Given this list of marker genes ITPR1 (NCBI Gene Id 619543, inositol 1,4,5-trisphosphate receptor type 1), CASP4, ERP29, CSNK1G3, ELL2 (NCBI Gene Id 22936), ADGRL2, ABCD1, PDE4B, AZIN2, NDUFA13, GOLGA7B, CRYZ, HSDL2, SCD, PRDX4, CCS, SIDT1, TMED3, RGS10, MYH9, FERMT3, TAX1BP1, EIF2B2, BCL2L14, INSIG2, RBM43, TK1, CR1L, UBR2, PRF1, ASPM, GNA13, NXPE2, FIS1, TUT4, MXD1, CMAS, POU6F1, FTH1, MKNK2, ARID1A, RNF130, YPEL2, ARL6IP5 (ADP ribosylation factor like GTPase 6 interacting protein 5), SHARPIN (SHANK associated RH domain interactor), CEP43, ANKRD50, KLF12, FXYD4, SLC39A13, SNX14, TRIB2, SCAND1, GPI, GABPB2, B3GALT4, SNX20, RBFOX2, CYSTM1, STMN1, C6orf118, CCL5, TAP2, MAMDC2, CERS6, MACO1, GAPDHS, PSRC1, DEPDC1B, ABHD17B, MAN2A1, USP38, IL1F10, TNFAIP6, CHIC2, BTD, ADGRE5, RNF169, NCAPG, TUBG2, SAMHD1, AUP1, PGM1, TK2, MCEE, RAP1A, CCM2, ZNF710, ANKLE2, IL18, SLC2A8, CD38, SERINC3, STS, CHCHD10, NTAQ1, NDUFS8, PDE1B, ASAP1, SGK1 (NCBI Gene Id 6446), RB1CC1, RP1L1 (RP1 like 1), FBXO33, DYNLT3, SLC52A3, BUB1B, HID1, NCF2, XPA, NAXE, HDAC5, SFMBT2, LTK, TBC1D4, ALDH2, BHLHE41, HYLS1, BMP2K, TMEM192, ABHD2, SCLY, SFT2D1, TMCC1, S1PR4, OPN3, CEP120, RASSF3, PCMTD1, NAT14, NT5C3A, YPEL3, OSTC, SOAT2, IGBP1, PARP11, CMIP, NSG2, HINT3, FAM174A, REST, SH3BP2, KRTAP12-2, PTPN18, RAPGEF4, SLC28A2, PLEKHA2, BAD, SMARCA2, CYB561A3, MFGE8, USP11, ATP6V0C, GALNT2, PLAGL1, MUC1, NUB1, ZNF23, AVL9, KIDINS220, CHMP5, NIPAL3, LRIG2, NCKAP1L, RBM47, DNAJC7, TOX2, TSPAN14 (tetraspanin 14), SUSD1, ATP6AP1, SMAP1, DPCD, LYNX1, CD209, EPOR, CD96, QPRT, ROPN1L, SDF4, ARSK, PLSCR3, TSPAN2, ARHGEF1, ASL, OAS1, CILK1, SUSD3, TMEM131, FCER1G, GAMT, NFIA (nuclear factor I A), SERHL2, SLAIN1, MAP1LC3A, GRINA, METTL21A, CD47, C8orf58, EIF3E, SLAMF7, MMAB (NCBI Gene Id 89909), here is a description of the gene set: species: Homo sapiens During acute viral infections, naïve CD8+ T cells differentiate into effector CD8+ T cells and, after viral control, into memory CD8+ T cells. Memory CD8+ T cells are highly functional, proliferate rapidly upon reinfection and persist long-term without antigen. In contrast, during chronic infections, CD8+ T cells become “exhausted” and have poor effector function, express multiple inhibitory receptors, possess low proliferative capacity, and cannot persist without antigen. To compare the development of functional memory T cells with poorly functional exhausted T cells, we generated longitudinal transcriptional profiles for each. Genes up-regulated in CD8 T cells: naïve versus effectors at day 8 chronic infection with LCMV-clone 13. from publication Doering TA, Crawford A, Angelosanto JM, Paley MA, Ziegler CG, Wherry EJ (PMID 23159438) Human Gene Set: GSE41867_NAIVE_VS_DAY8_LCMV_CLONE13_EFFECTOR_CD8_TCELL_UP